Given this list of marker genes Sirpa, Defb21, Trim30c, Cd14, Trib1, Ly96, Cd55, Nfkbil1, Mif, Tut4, Cd84, Cx3cl1, Sash1, Tnfaip3, Trim30b, Ptpn6, Cactin, Prdx2, Trim12a, Ly86, Trim5, Cd55b, Trim30a, Trim30d, Acod1, Bmp6, Scimp, Ptpn11, Ltf, Cd180, Prkca, Traf6, Trim12c, here is a description of the gene set: studied in species Mus musculus Any process that modulates the frequency, rate or extent of signaling in response to detection of lipopolysaccharide. Mouse Gene Set: GOBP_REGULATION_OF_LIPOPOLYSACCHARIDE_MEDIATED_SIGNALING_PATHWAY